Given this list of marker genes SPHK2, SPHK1, GPR6, S1PR2, S1PR1, S1PR4, S1PR5, GPR3, S1PR3, here is a description of the gene set: Human Gene Set: GOMF_SPHINGOSINE_1_PHOSPHATE_RECEPTOR_ACTIVITY Combining with the sphingolipid sphingosine-1-phosphate (S1P), and transmitting the signal across the membrane by activating an associated G-protein. species: Homo sapiens